The following is a description of a gene set: Mouse Gene Set: GOBP_NEGATIVE_REGULATION_OF_BINDING Any process that stops or reduces the rate or extent of binding, the selective interaction of a molecule with one or more specific sites on another molecule. studied in species Mus musculus, and this is the list of marker genes: Tdg (thymine DNA glycosylase), Rgma, Bag2, Itga4, Xirp1, Pabpn1l, Ccm2l, Cdkn2a, Msx1, Kdm1a, Atp2a2, Akt1, Jak2, Aurkb, Cpne1, Dkk1, Camk1, Styx, Pin1rt1, Lrrk2, Slpi, Usp33, Ppp3ca, 1810037I17Rik, Frmd7, Hand1 (heart and neural crest derivatives expressed 1), Tle5, Dtnbp1, Crtac1, Itgb1bp1, Aurka, Tmc8, Lef1, Lhx2 (NCBI Gene Id 16870), Styx-ps, Tfip11, Wfikkn2, Shh, Ralb, Id2, Rsf1, Sln, Nfatc4, Bax, B2m, Larp7 (NCBI Gene Id 652994), Msx2, Ptprf, Efhb, Smo, Mapk3 (mitogen-activated protein kinase 3), Ifi214, Zfp90, Sox11, Hand2, Habp4, Mad2l2, Cdkn1a, Ifi208, Zfp462, Gtf2f1, Myod1, Ifi207, Sp100, Mepce, Hfe, Mndal, Carm1, Ybx2, Pcsk9, Ttc36, Ctnnbip1, Tmbim6, Twist2, Ifi203, Rack1, Tex14, Ttbk1, Tfap4, Ifi209, Gtpbp4, Ilrun, Ifi203-ps, Sumo1, Nfib, Adam15, E2f1, Dhrs7b, Arhgap28, Pex14, Psen1, Wfikkn1, Atp2a3, Ifi213, Sympk, Fbh1, Dact1, Mdfi, Psme3ip1, Gzma, Hmga2, Adipoq, Zfpm1, Ifit2, Ddx11, Id1, Pim2, Mitd1, Gemin2, Il10, Plscr1, Park7, Mrln (NCBI Gene Id 69563), Dnajb2, Pdgfb, Pex19, Wapl, Tnks, Nek2, Hey2, Golga2, Pln, Ifi206, Fbxw7, Mapk8, Gnl3l (NCBI Gene Id 237107), Dab2, Btaf1, Senp2, Sumo3, Rock1, Nes, Jun, Smim6, Lrpap1, Myc, Ttbk2, Stub1, Ckmt1, Pin1, Epb41l5, Nog (noggin), Gata1